Given this list of marker genes Col6a6, Col6a2, Bgn, Dmp1, Dcn, Acan, Col5a1, Col5a3, Col5a2, Agrn, Itga2, Col6a3, Vcan, Tnr, Itga7, Itgax, Col6a5, Itgav, Col6a1, Hapln1, Tnn, Itgb3, Col1a2, Itga8, Vtn, Itga9, Col9a3, Bcan, Matn1, Tnxb, Matn4, Col2a1, Itgb1, Dspp, Col3a1, Itgb6, Col9a1, Col9a2, Serpine1, Fn1, Matn3, Col1a1, Itga2b, Tnc, App, Comp, Sparc, here is a description of the gene set: species: Mus musculus ECM proteoglycans Mouse Gene Set: REACTOME_ECM_PROTEOGLYCANS